Given this list of marker genes Slc22a5, Slc22a3, Slc22a1, Slc22a16, Slc22a2, Slc22a18, Slc47a1, Slc14a2, here is a description of the gene set: part of: SLC-mediated transmembrane transport electronically inferred by orthology from the curated human pathway This event has been computationally inferred from an event that has been demonstrated in another species.<p>The inference is based on the homology mapping from PANTHER. Briefly, reactions for which all involved PhysicalEntities (in input, output and catalyst) have a mapped orthologue/paralogue (for complexes at least 75% of components must have a mapping) are inferred to the other species. Reactome Pathway: SLC-mediated transport of organic cations species: Mus musculus